The following is a description of a gene set: A process in which an regulatory non-coding RNA molecule reduces expression of target genes. This can occur pre-transcriptionally by assembly of heterochromatin and prevention of transcription or co- or post-transcriptionally by targeting RNAs for degradation or by interfering with splicing or translation. This process starts once the inhibitory RNA molecule has been transcribed, and includes processing of the RNA such as cleavage, modifications, transport from the nucleus to the cytoplasm, loading onto the RISC complex, and the effect on transcription or translation. studied in species Mus musculus Mouse Gene Set: GOBP_REGULATORY_NCRNA_MEDIATED_GENE_SILENCING, and this is the list of marker genes: Ago1, Ago2 (argonaute RISC catalytic subunit 2), Mirlet7b, Zfp36, Srrt, Mir124a-3, Mir9-1, Hnf1a, Cnot9, Mael, Pum2, Lin28a, Dgcr8, Tial1, Mir874, Eri1, Dnmt3a, Zswim8, Stat3, Mir124a-1hg, Mir489, Bmp4, Elob, Cnot2, Henmt1, Tdrd6, Mir26b, Hnrnpk, Drosha, Mir301, Mir221, Gpat2, Tex15, Mir21a, Mir451b, Tnrc6a, Adar, Wtip, Morc1, Il6, Mir495, Tent2, Piwil1, Mir34a, Mir214, Pnldc1, Mir7-2, Cnot10, Mir146, Mir124-2hg, Zc3h7a, Eif6, Mir7578, Mir1a-2, Mirlet7e, Mir155, Cnot3, Mir186, Nup155, Dicer1, Tert, Mir23a, Helz2, Fxr1, Mir129-2, Tnrc6b, Mir451a, Xpo5, Gm38999, Mir143, Trp53, Mir196a-2, Mir511, Mir361, Mirlet7a-1, Asz1, Ddx17 (NCBI Gene Id 97974), Srsf3, Mov10, Mecp2, Tdrkh, Fmr1, Zmpste24, Exd1, Mir26a-2, Mir423, Mir30a, Mir133a-1, Mir875, Piwil4, Mir133a-2, Eif4g1, Mir137, Cnot7, Limd1, Ncbp2, Mir1a-1, Mir107, Tgfb1, Znfx1, Mir324, Tsn, Mirlet7a-2, Mir668, Mir494 (NCBI Gene Id 723878), Mir21c, Clp1, Tsnax, Eif4e2, Mir135a-1, Prkra (protein kinase, interferon inducible double stranded RNA dependent activator), Mirlet7c-1, Mir100, Spin1, Mir124a-1, ENSMUSG00000126352, Arb2a, Mir129-1, Zc3h7b, Hnrnpa2b1, Cnot1 (CCR4-NOT transcription complex, subunit 1), Mir183, Ddx5, Mir26a-1, Trim71, Hnrnpu, Mov10l1, Mir182, Mir3960, Snip1, Tut7, Cnot6l, Helz, Ddx4, Tut4, Dnmt3l, Cnot11, Ajuba, Gtsf1, Zc3h10, Mir196a-1, Pum1, Spout1, Nrde2, Chaserr, Mir223, Tdrd9 (tudor domain containing 9), Dnd1, Lin28b, Mir505, Mir125b-2, Mir205, Bcdin3d, Tnrc6c, Mir203, Fkbp6, Mir450b, Mir10a, Tdrd12, Carlr, Mir1247 (microRNA 1247), Cnot8, Mir200b, Mir21b, Ncbp3, Mir7-1, Mir154, Fbxo24, Mirlet7c-2, Parn, Rbm4, Ago3, Ddx3x, Pus10, Elavl1, Hotair, Ncbp1, Airn, Rbm3, Tdrd5, Spocd1, Dhx9, Mir124a-2, Tdrd7, Ezh2, Eif4enif1 (eukaryotic translation initiation factor 4E nuclear import factor 1), Mir17, Eloc, Mir96, Dnmt3b, Snd1, Tarbp2, Mirlet7g, Ripk1, Tdrd1 (NCBI Gene Id 83561), Mir200a, Trub1, Ddx6, Mir351, Mir125b-1, Mir504, Cnot6, Mir101a, Mir125a, Mir196b, Mettl3, Pabpc1, Pld6, Ago4, Piwil2, Mir101b, Mir873a